The following is a description of a gene set: studied in species Homo sapiens A region of the nuclear envelope to which a microtubule organizing center (MTOC) attaches; protein complexes embedded in the nuclear envelope mediate direct or indirect linkages between the microtubule cytoskeleton and the nuclear envelope. Human Gene Set: GOCC_MICROTUBULE_ORGANIZING_CENTER_ATTACHMENT_SITE, and this is the list of marker genes: SYNE1, SYNE4, SPAG4, SYNE3, SUN3, SUN1, SYNE2, SUN5, SUN2, CLMN, KASH5